Given this list of marker genes REEP1, MPZ, CHCHD10, GARS1, PMP22, BSCL2, CPT2, here is a description of the gene set: Cold-induced muscle cramps Human Gene Set: HP_COLD_INDUCED_MUSCLE_CRAMPS species: Homo sapiens Sudden and involuntary contractions of one or more muscles brought on by exposure to cold temperatures.